Given this list of marker genes Mthfd2l, Aldh1l2, Mthfd1l, Mthfd1, Aldh1l1, Aasdhppt, here is a description of the gene set: The chemical reactions and pathways involving 10-formyltetrahydrofolate, the formylated derivative of tetrahydrofolate. Mouse Gene Set: GOBP_10_FORMYLTETRAHYDROFOLATE_METABOLIC_PROCESS species: Mus musculus